The following is a description of a gene set: Late basal from publication He P, Lim K, Sun D, Pett JP, Jeng Q, Polanski K, Dong Z, Bolt L, Richardson L, Mamanova L, Dabrowska M, Wilbrey-Clark A, Madissoon E, Tuong ZK, Dann E, Suo C, Goh I, Yoshida M, Nikolić MZ, Janes SM, He X, Barker RA, Teichmann SA, Marioni JC, Meyer KB, Rawlins EL (PMID 36493756) studied in species Homo sapiens Human Gene Set: HE_LIM_SUN_FETAL_LUNG_C1_LATE_BASAL_CELL, and this is the list of marker genes: ALPL, A4GALT, JAG2, UBD, KRT15 (keratin 15), SFN, FHL2, EMP1, TP63, PTGS2, LHFPL6, KLF2, PRNP, S100A2, KRT5, CH25H, KITLG (NCBI Gene Id 780897), WIPI1, RGS10, EHF, TFAP2A, EPAS1, CCNO, PDLIM2, EYA1, RARB, LMO3, TMEM150C, PAX9, OPTN, CDKN1A, ST6GALNAC2, PTPRE, NPPC, DKK3, STOM, SPINK5, FJX1, ACTA2, VCAN, GPC3, CLDN1, GABRA1, FXYD5, CLDN10, NBL1, CXCL6, LYPD6B, NTN1, CYP2S1, CXCL1, COL1A2, SULT2B1, ARSJ (NCBI Gene Id 79642), TIMP1, CPNE8, RGCC, SIX1 (NCBI Gene Id 6495), EVA1C, MYC, CFH, MT1E, REEP2, SLC5A7, TMEM40, GCLC, CCDC122, SCNN1B, SOSTDC1, MEG3, COL7A1, MARVELD1, FHL1, SCNN1G, ANXA1, LGALS7B, HS3ST1, GNG12, NTF3, WNT4 (NCBI Gene Id 54361), DLK2, NRG1, PKP1, ABI3BP, RND3, COL14A1, GCNT1, TPM2, LPCAT2, CHST9, F3, EGR3, DST, LGALS1, EYA2, IL33, EHD2, BOC, RASSF6, CASP1, CAPNS2, HLA-B, PMAIP1 (phorbol-12-myristate-13-acetate-induced protein 1), FRZB, FBXO32